Given this list of marker genes Masp1, Colec11, Masp2, Colec10 (collectin sub-family member 10), Mbl2, Fcna, Fcnb, here is a description of the gene set: Lectin pathway of complement activation Mouse Gene Set: REACTOME_LECTIN_PATHWAY_OF_COMPLEMENT_ACTIVATION studied in species Mus musculus